Given this list of marker genes SEMA6C, GGPS1, SRSF7, SPTB, DLX1, TMEM187, EML3, RPS6KA5, BLTP3A, HOXA3, MSANTD2, RNF145, COL1A2, MAP3K20, FLJ40288, CPNE1, STRADB, TMEM125, JADE2, RAB6B, TIMM10, NKAIN3, PLEKHA1, OAZ2, SLC1A7, LPAR2 (lysophosphatidic acid receptor 2), NDST3, NNAT, FGF11, CAMKK2, GNRHR2, MYH6, ASIC3, TLE6, FOXP1, TOX2, PPARD, PHLDB3 (pleckstrin homology like domain family B member 3), NXPH4, NPTX2, FRMD4A, GAD1, COL11A2, RELL2, RNF11, PYY, EYA1, TMEM95, TAOK2, TEAD3, PEX11B, ZBTB4, NDUFS4, TP53INP2, ACACA, SLC6A14, PUM2, SALL2, GSX1, LYRM1, ADD3, POLR2A (NCBI Gene Id 5430), STXBP4 (syntaxin binding protein 4), C6orf136 (chromosome 6 open reading frame 136), NALF2, EDN1 (NCBI Gene Id 1906), ZNF513, ATP5MC3, GRHL2, ELAVL2, SPATA32, UQCRC1, ADNP, LRRC8D, MED26, DMD, PCSK1N, PODXL2, MYH13, DLG2 (NCBI Gene Id 283225), NFKBIA, ITSN2, UBE2D3, IL34, PGF (placental growth factor), SKA2, NRG1, SYT17, NR1D1, NDUFS2, LRRC74A, RAB10, TGIF2, ARID4B, GNB2, CHMP2B, CDK17, SPEM1, PRRG4, FAF2, OPTN, PIAS1, NLGN3, CD248, SLC7A9, LENG9, CHRFAM7A, UBE2H, ZNF385A, AMD1, GLI1, HRH3, ENO2, ERBB3, ZMYM2, TAF10, MAP1LC3A, ELAVL4, ADM, LY6G5B, KIR3DX1 (NCBI Gene Id 90011), NR2E1, TAOK3, PIK3AP1 (phosphoinositide-3-kinase adaptor protein 1, NCBI Gene Id 118788), GART, URB1-AS1, ID2, BNC2, OLIG3 (NCBI Gene Id 167826), LIN28A, MAP4K4, HOXD4, AMHR2, ING2, RARA, ZMYM3, LIPG, ZBTB20, GDNF, LHX4, NELL2, NUFIP2, DUSP10, DDX17, SRCIN1, ACTA1, ATP5MC1, SENP1, NPEPPS, EBF2, SGK1, POLA1, CX3CL1, MID1IP1, RB1CC1, NEUROG1, FOXD3, LRRC3B, RREB1, PDGFB, SOX5, MEIS2, CHCHD1, MTRFR, ADAMTS4, LINC00670, ARHGAP36, NACC1, COL4A4, HS3ST3A1, DSC1, KCNQ1DN, PTK2B, FOXP2, TMCO4, NIPBL, PTK7, ZIC2, PRR11, TGOLN2, OBSCN, NOVA1, ESRRA, LAMA4, DTX3, NREP, RELA, ATP1A2, ABCG1, ATP1B1, PDGFRL, ACSL3, HMGB1, MPZL3, CYP2B6, ADAM9, SON, TM2D2, STAG2, MITF, PRSS27, OGN, BZW1, CTBP2, HDAC4, SIK1, ZNF213, LRP3, APOC1, BCL3, RBM39, RTL9, STAC2, PLAG1, JARID2, RCC2, COX11, COL4A3, PHF12, KDM3B, TNFRSF12A, TFEB, KCND3, BMI1, PRMT3, RASGRP2, RASL11B, TGFB3, CIC, DCX, LPCAT3, EIF4G1, FBXO40, KDM6A, MOV10, ABCA1, RSBN1, ACER3, POLR3C, OTUD7B, GJD2, ARMC12, DCUN1D3 (NCBI Gene Id 123879), KLF14, MIDEAS, SOX15, IP6K2, FKBP2, ACY1, DCLK2, GREM1, CRABP2, SCML1, NR5A2, IL11 (NCBI Gene Id 3589), TMEM135, ARHGAP24, POU2AF1, ZBTB21, AMMECR1, UPF2, SCAMP3, APLP2, TRAK2, ERRFI1 (ERBB receptor feedback inhibitor 1), ELOA2, here is a description of the gene set: Human Gene Set: DR4_Q2 Genes having at least one occurrence of the motif YGAMCTNNASTRACCYN in the regions spanning 4 kb centered on their transcription starting sites. This matches the RXRB transcription factor binding site V$DR4_Q2 (v7.4 TRANSFAC). species: Homo sapiens